The following is a description of a gene set: species: Mus musculus Mouse Gene Set: GOBP_INTERLEUKIN_10_PRODUCTION The appearance of interleukin-10 due to biosynthesis or secretion following a cellular stimulus, resulting in an increase in its intracellular or extracellular levels., and this is the list of marker genes: Nfkbiz, Foxp3, Psg18, Trem2, Hspd1, Tslp, Dll1, Il6, Pycard, Prg2, Hmgb1, Il23a, Ptger4, Syk, Ido1, Il20rb, Irf4, Fcgr2b, Il12b, Trib2, Isg15, Vsir (V-set immunoregulatory receptor), Tnfsf18, Cd274, Tnfrsf21, Il13, Nod2, Cd46, Xcl1, Cd40lg, Inava (NCBI Gene Id 74329), Prkcd, Clec7a, Il4, Pibf1, Rad21, Il21, Mir98, Cd83, Pdcd1lg2, Tyrobp, Lilra5, Btk, Plcg2, Cd84, Tnfsf4, Cd28, Lgals9 (NCBI Gene Id 16859), Fcer1g, Tlr4, Prkcz, Lilrb4a, Jak3, Tigit, Lilrb4b, Stat3, Tusc2, Bcl3, Il23r, Epx (eosinophil peroxidase), Sash3, Tlr9, Rbm47, Cd47 (CD47 antigen (Rh-related antigen, integrin-associated signal transducer)), Ager, G6pdx, Tlr2, F2rl1, Hgf